The following is a description of a gene set: Mouse Gene Set: CUI_NK_CELL_IL15_RESPONSE_UP species: Mus musculus Genes positively differentially expressed in cell type: NK cell upon treatment with cytokine: IL-15 in mouse lymph nodes in vivo. Cytokines mediate cell-cell communication in the immune system and represent important therapeutic targets. A myriad of studies have highlighted their central role in immune function, yet we lack a global view of the cellular responses of each immune cell type to each cytokine. To address this gap, the authors created the Immune Dictionary, a compendium of single-cell transcriptomic profiles of more than 17 immune cell types in response to each of 86 cytokines (>1,400 cytokine-cell type combinations) in mouse lymph nodes in vivo. A cytokine-centric view of the dictionary revealed that most cytokines induce highly cell-type-specific responses. For example, the inflammatory cytokine interleukin-1β induces distinct gene programmes in almost every cell type. A cell-type-centric view of the dictionary identified more than 66 cytokine-driven cellular polarization states across immune cell types, including previously uncharacterized states such as an interleukin-18-induced polyfunctional natural killer cell state. from publication Cui A, Huang T, Li S, Ma A, Pérez JL, Sander C, Keskin DB, Wu CJ, Fraenkel E, Hacohen N (PMID 38057668), and this is the list of marker genes: Eef1akmt4, Prep, Ccl3, Znrd2, Cdv3, Cct5, Erh, Trim30a, Ssr2, Nabp1 (NCBI Gene Id 98468), Comtd1, Ddx27, Larp1, Tspan4, Tmed2 (transmembrane p24 trafficking protein 2), Pbdc1, Nol11, Ppm1g, Hspd1, Got2, Tmem147, Tm9sf4, Nap1l1, Smchd1, Serbp1, Prps1, Ncl (NCBI Gene Id 319677), Eif5b (eukaryotic translation initiation factor 5B), Ywhae, Ube2s, Hspe1, Mogs, Timm8b, Kcnq1ot1, Uchl3 (NCBI Gene Id 50933), Ifrd1, F2r, C1qbp, Hsp90b1, Npepl1, Nop2, Rnf126, Bccip, Tmem33, Ppp1r11, Strap, Set, Slc30a5, Slc39a6, Riok1, Ube2i, Nsun2, Rpn1, Pdcd1lg2, Szrd1, Furin, Tma16, Txn2, Lsm6, Mrps17, Srsf10, Mettl1, Nsfl1c, Thop1, Wdr46, Grpel1, Polr2k, Prpf31, Nop14, Npm1, Dazap1, Bzw2, Nfkbib, Psme2, Ssb, Mdn1, Eny2, Tcerg1, Ndufc2, Brix1, Eif3d, H13, Mgat2, Epop, Hspa8, Zfp706, Txn1, Tma7, Nedd8, Bspry (NCBI Gene Id 192120), Rnf19b, Aatf, Polr1d, Isg15, Nop16, Mrps33, Polr3d, Eif2b3, Setbp1, Timm50, Mrps14, Ssbp1 (NCBI Gene Id 72790), Sub1, Dnajb11, Ola1, U2af1, Gars1, Timm17a, Spcs2, Zbp1, Cish, Srsf7 (NCBI Gene Id 60426), Vars1, Psma7, Ubap2, Ydjc, Rrp1 (ribosomal RNA processing 1), Ldha, Styk1, Prmt7 (NCBI Gene Id 71012), Kars1, Lyar, Impdh2, Ppia, Mapk6, Exosc5, Tmem167, Snhg12, Pak1ip1, Gemin2, Wdr12, Dnaja2, Pfdn2, Ubl4a, Tmed5, Mrpl11, Ctps1, Yrdc, Dus1l, Osm (oncostatin M), Nucks1, Capg, Eif1a, Tomm22, Atp5mf, Psmg2, Mrto4, Bop1, Metrnl, Sec61b, Psmd1, Cxcl10, Zranb2, Ndufa12, Tomm40, Ifi35, Cetn3, Emc4, Mrps28, Psma4, Dimt1, Cops6, Rabggtb, Banf1 (NCBI Gene Id 98145), Ifrd2, Snrpa, Fam162a, Dctpp1, Atp5mc3, Mrpl57, Eif6, Atp5mc1, Cope, Isg20, Nup62, Hnrnpu, Ccdc124, Imp4, Lrrc59, Ddx18, Cd69, Orai1, Cd53, Hnrnpa2b1, Taf10 (NCBI Gene Id 24075), Pole3, Atic, Stat3 (NCBI Gene Id 68733), Eef1e1, Gtf2f2, Txnl1, Aen, Rars1, Psmg4, Tkt, Anapc15, Ppp1r2, Heatr1, Pdap1, Rbm25 (RNA binding motif protein 25), Nasp, Thumpd1, Hars1, Yipf6, Sco2, Ftsj3, Mthfd1, Emc6, Nfkbiz, Prf1, Aprt, Mthfd2 (methylenetetrahydrofolate dehydrogenase (NAD+ dependent), methenyltetrahydrofolate cyclohydrolase), Pdcd5, Bzw1, Psmd12, Klhdc4, Rhoq, Atp5mk, Eif2s2, Dad1, Ufm1, Rnf7, Arf6, Cd320, Agpat5, Rwdd4a, Pa2g4, Shmt2, Cox5b, Ssrp1, Hirip3, Mgat4a, Hnrnpm, Mdh2, Snu13, Elob, Pam16, Sec61g, Ndufaf4 (NADH:ubiquinone oxidoreductase complex assembly factor 4), Fkbp2, Baz1a, Ebna1bp2, Ostc, Cox7c, Morf4l2, Rbmxl1, Metap2, Psmc2, Ifng, Chchd4, Rad23a, Gt(ROSA)26Sor, Ak2, Ppp1r14b, Cad, Ubald2, Gcsh, Mrpl12 (mitochondrial ribosomal protein L12), Srrm1, Cops7a, Sytl3, Trgc1, Tmed10, Nfil3, Srsf3, Exosc8, Xbp1, Il2rb, Actg1, Creld2, Uqcrq, Arpp19, Mrps15, Nudt5, Cox7b, Polr2h, Gnl3, Pcgf6, Sec13, Smyd5, Thyn1, Pycr3, Nol10, Eif3i, Cct8 (NCBI Gene Id 12469, chaperonin containing TCP1 subunit 8), Ube2v2, Stoml2, Pebp1, Uqcr10, Il2ra, Trir, Slc25a5, Cebpz, Serp1, Atad3a, Phb1, Cmss1, Bcl3, Hsp90ab1, Psat1, Canx, Gar1, Smndc1, Ywhab, Sod2, Vps37b (vacuolar protein sorting 37B), Naa20, Rnf157, Sh3bp2, Aimp1, Ssr1, Dnajc8, Crlf2, Utp4, Ccr5, Snrpd2 (small nuclear ribonucleoprotein D2), Bysl, Serpinb9, Lsm3, Ciao2b, Utp6, Parp9 (NCBI Gene Id 80285), Psmc4, Mrps7, Nudcd2, Eif1ad, Spcs3, Hint1 (histidine triad nucleotide binding protein 1), Lap3, Tgfb1, Lman2, Ubfd1, Atp2a2, Arpc1b, Skic3, Ssr4, Myc, Mapkapk2, Gtf2f1, Eloc, Alg5, Srm, Cyc1, Sult2b1, Snrpe, Zc3h15, Stt3a, Exosc2, Eif4a3, Dcun1d5, Psme3, Apex1, Phf5a, Prpf40a, Psma6, Sar1a, Eif2s1, Hnrnpdl, Gnl2, Relb, Socs1, Znhit6, Dnajc2, P4hb, Ezr, Nhp2, Eif3g, Timm10, Tnfrsf9, G3bp1, Ybx3 (Y box protein 3), F2rl2, Tmem238, Cox5a, Glrx5, Eif5a, Noa1, Jagn1, Hnrnpa1, Mrpl19, Nmd3, Ewsr1, Cacybp, Litaf, Prelid3b, Chmp4b, Polr1g, Pfn1, Pkm, Atp6v1g1, Pus7, Nop56, Cfdp1, Knop1, Selenos, Gimap5, Manf, Bcl2a1b, Psme1, Sem1, Hras, Pim3, Slc1a5 (NCBI Gene Id 269874), Btf3, Emg1, Lta, Mafg, Ppa1 (pyrophosphatase (inorganic) 1), Anp32b, Pcbp1, Fbl, Hectd1, Mif, Med21, Atp5f1d, Psma3, Eef1d, Ube2m, Serpina3f, Nifk, Tmem11, Cluh, Srsf2, Rbm3, Ppig, Uap1, Mrps24, Slc35b1, Nme1, Nol8 (NCBI Gene Id 70930), Nadk, Eif5, Rrp9, Mrpl54, G6pc3, Lilrb4b, Eprs1, Calu, Dynll2, Trmt6, Bhlhe40, Snrpf, Pusl1, Timm9, Nol12, Noc2l, Denr, Pabpc4, Ubap2l, Smarca4, Psmb5, Hnrnpf, Picalm, Zfp593, Bst2, Cox7a2, Ndufaf8, Atf6b, Trmt1, Ppp5c, Eci1, Timm13, Timm8a1, Lsm7, Snd1, Mphosph10, Rrs1, Ube2n, Abce1, Slc29a1, Snrpd1, Cyb5b, Slc19a1, Nars1, Fubp1, Socs3, Cmas, Rbm8a, Cxcl9, Iars1, Slc16a6, Aim2, Gps1, Zmynd19, Mrps5, Nip7, Pop7, Kdm6b, Ddx21, Mrpl20 (NCBI Gene Id 73950), Myl12a, Nop10, Bcl2, Sh2d2a, Crem, Fkbp1a, Trnau1ap, Ppan, Rsl24d1, Ran, Pum3 (pumilio RNA-binding family member 3), Imp3, Mrpl52, Eif3c, Nol6, Pals2, Cnbp, Stt3b, BC035044, Eif2s3x, Aimp2, Eif3j1, St6galnac4, Ccnd2, Ifi204, Bola3, Gsto1, Ndufb2, Lsm12, Nudt9, Irf8, Gmfb, Pvt1, Eif1, Lilrb4a, Odc1, Srsf6 (NCBI Gene Id 98904), Ly6a, Alkbh1, Pprc1, Eif4e, Igtp, Hnrnpc, Mrpl21, Mrpl36, Cdk4, Casp8, Eif3b, Npm3, Bax, Ptges3, Taf1d, Trp53, Gosr2, Snrpb, Ncr1, Prmt1, Caprin1, Emc7, Pdia6, Tbl3, Ndufb6, Trim28, Chchd1, Pim2, Pwp1, Snhg6, Ndufa4, Jpt1, Lig3, Ranbp1, Hnrnpa3, Abcf1, Fasl, Dis3, Ifitm3, Hspa9, Slc7a1, Rrp15, Hsp90aa1, Pdia3, Eif1ax, Magohb, Dph3, Larp4, Serpina3g, Zcrb1, Tars1, Pin1, Ero1a, Atp5pb, Eno1, Ndufab1, Ndufa5, Fam133b (NCBI Gene Id 72939), Ap2m1, Cox6a1, Syncrip, Pgk1, Dkc1, Xcl1, Gfpt1, Lcp1, Nufip1, Psmc5, Rsl1d1, Nek6, Polr2f, Llph, St13, Tomm5, Stip1, Psmd3, Dgat1, Usp14, Mrpl23, Magoh, Tuba4a, Ptma, Tubb4b, Hspa4, Eef1g, Psmb6, Pno1, Cct7, Top1 (topoisomerase (DNA) I), Naca (nascent polypeptide-associated complex alpha polypeptide), Ruvbl2, Sdad1, Naa15, Esf1, Rangrf, Gadd45g, Gmds, Prpf4, Snrpa1, Nudc, Ruvbl1, Mrpl35, Sf3a1, Kti12, Etf1, Rwdd1, Sar1b, Cinp, Serpinb6b, Rcc2, Nup205, Rrp7a, Noc3l, B3galt6, Hnrnpa0, Anp32e, Agpat3, Gimap4, Csrnp1, Mrpl41, Uck2, Wdr4, Mrpl15, Runx3, Tmed9, Psmb4, Vdac2, Afg2a, Psmb2 (proteasome (prosome, macropain) subunit, beta type 2), Nus1, Hdgf, Xpot, Tmem248, Pfdn4, Icam1, Uqcc2, P2ry14, Ybx1 (NCBI Gene Id 97156), Pgam1, Eif4h, Hdlbp, Gzma, Cfl1, Bola2, Tex2, Atp5f1b, Uqcrb, Tsr1, Farsa, Hprt1, Trgc4, Cct2, Eif4g1, Pfdn6, Ppp3cb, Syce2 (synaptonemal complex central element protein 2), Fcf1, Tcp1, Gpatch4, Wdr43, Mybbp1a, Mydgf, Chd1, Polr2l, Cotl1, Nolc1, Uqcr11, Arfrp1, Cers2, Mbd3, Gnpnat1, Aurkaip1, Srsf9, Arl1, Umps, Hnrnpd, Gls, Cdk6, Itpk1, Slamf7, Ltv1, Bcap29, Rnf213 (ring finger protein 213), Rexo2, Ube2l3, Tomm20, Alyref, Rpf2, Gpr18, Clptm1l, Mrpl17, Mettl16, Dohh, Stk39, Nop58, Atp5pf, Gimap7, Bsg, Utp14a, Tcof1, Calr, Psmd7, Ppid, Tuba1c, Nle1, Ube2f, Phb2, Prdx1, Gtpbp4, Chsy1, Higd1a, Kpna1, Sf3b3, Gspt1, Ddost, Rbbp7, Exosc3, Ddx39a, Psma2, Arf1, Pomp, Utp18, Krtcap2, Plscr1, Sumo2, Abcf2, Surf2, Sms, Eif3a, Gzmb (granzyme B), Mak16, Pdcd11, Ddx24, Prmt3, Snrpd3, Ipo4, Pim1, Mat2a, Hnrnpab, Gart, Wdr83os, Erap1, Cops4, Wdr18, Slc39a7, Rrp1b, Psma5, Tes, Mctp2, Ddx10, Naa25, Mtdh, Ntmt1, Pdia4, Vapa, Sfxn1, Trappc6b, Hspa5, Jaml, Ndufb4, Eif4a1, Ccl4, Dnajc11, Cycs, Cct3, Txnl4a, Sdf2l1, Idh3a, Phgdh (NCBI Gene Id 50895), Rbm17, Magt1, Rpp14, Psmd11, Gpr171, Trmt61a, Tomm70a, Lars1, Ppif, Tagln2, Cct4, Pole4